Given this list of marker genes Col5a1, Lama1, Igfbp7, Col2a1, Col1a1, Tgfbi, Tnc (NCBI Gene Id 21923), S100a6, Col10a1, Nid2, Pxdn, Ltbp2, Col11a2, Col6a2, Anxa6, S100a10, Nid1, Fn1, Col6a1, Agrn, S100a11, Col3a1, Serpinh1, Anxa4, Col5a2, Itih4, Col16a1, Col14a1, Eln, here is a description of the gene set: studied in species Mus musculus Matrisome proteins detected in significantly different abundance in lymph node metastasis arising from KP primary tumors as compared to normal lung. from publication Gocheva V, Naba A, Bhutkar A, Guardia T, Miller KM, Li CM, Dayton TL, Sanchez-Rivera FJ, Kim-Kiselak C, Jailkhani N, Winslow MM, Del Rosario A, Hynes RO, Jacks T (PMID 28652369) Mouse Gene Set: NABA_MATRISOME_METASTATIC_LUNG_LYMPH_NODE_METASTASIS In this study, we investigated the role of the extracellular matrix (ECM) in the underlying biology of lung adenocarcinoma using an autochthonous mouse model that recapitulates the complexity of cancer initiation and progression to characterize the ECM composition of normal lung, fibrotic lung, lung tumors, and metastases. We isolated normal, healthy lung tissues from wild-type (WT) mice and microdissected KrasG12D/p53-/- primary lung tumors (KP tumors) and associated metastases to the mediastinal lymph node. Quantitative mass spectrometric profiling of the ECM composition of normal lung, fibrotic lung (from bleomycin-treated mice), primary lung tumors, and lung metastases to the lymph nodes uncovered specific signatures distinguishing these tissues. This gene set lists the matrisome proteins detected in significantly different abundance in lymph node metastasis arsing from KP primary tumors as compared to normal lung.